The following is a description of a gene set: Neighborhood of EIF3S6 Human Gene Set: MORF_EIF3S6 Neighborhood of EIF3S6 eukaryotic translation initiation factor 3, subunit 6 48kDa in the MORF expression compendium studied in species Homo sapiens, and this is the list of marker genes: HDAC1 (NCBI Gene Id 3065), MACROH2A1, SKP1, SNRPA, HNRNPA1 (heterogeneous nuclear ribonucleoprotein A1), ANP32B, PSMB1, LETMD1, RACK1, COX7C, CYC1, ATP5PO (ATP synthase peripheral stalk subunit OSCP), COX4I1 (cytochrome c oxidase subunit 4I1), U2AF1, BTF3, EIF3K, CCT2, COX7A2L, HNRNPC, NPM1, SET, HNRNPUL1, SF3A2, MTDH, GDI2, RAD23A, EEF1D, UQCRH, YWHAQ, CTDNEP1, PPP2R1A (NCBI Gene Id 5518), SNX3, VDAC2, COX5B, CCT7, RPL24, IST1 (IST1 factor associated with ESCRT-III), HSP90AB1, DDOST, RAB8A, EIF3M, EIF3G, ERP29, LYPLA1, RPL21 (NCBI Gene Id 6144), PCBP2, RPL22 (NCBI Gene Id 65281), RPL6, RPS12, RPS27A, SLC25A3, EIF3H, TAF11, EIF3D, AP3S1 (adaptor related protein complex 3 subunit sigma 1), RPS6, RPL5, UQCRC2, HADHB, SSR2, NDUFV1, IFRD1, RBMX, EIF3E, TKT, RPL10A, SRSF9, EIF4A1, FBL, ANAPC5, JTB, COPS5, NAP1L1, CNBP, RPL14, ACP1, SMARCD2, PCMT1, EIF4H, DAZAP2, EIF4B, YWHAZ, RPL30, UBA2, RAN, DRG1, RPLP2, SRP14, HADHA (NCBI Gene Id 3030), TCEA1, KHDRBS1, CANX, HSP90AA1, PARK7, NDUFS4, SH3BGRL, UQCRFS1, HDGF, RPL7, RSL1D1, KXD1, DDX39B, CCNI, H2AZ2, SRSF3, STARD7, RPS24, HMGN1, NONO, RPL18, MDH1, FAU, DDX49, CBX3, SNRPE (NCBI Gene Id 6635), NACA, UQCRB, EEF2, NCL, EIF4A2, MRPL9, SUMO2